Given this list of marker genes DUOXA2, GLI2, CDKN1C, SH3PXD2B, BMPER, ARX, LRP2, TG, CHUK, HSD17B4, LMNA, FIG4, KCNQ1OT1, HOXD13, PEX26, ETFDH, COL11A1, NDUFAF3, TWIST1, RNU12, VDR, TSHB, KCNQ1, EP300, DICER1, INTU, MTOR, MEG3, IGF2, MASP1, FLNA, ALG8, SEC23A, PIGQ, PEX19, PTDSS1, ACTB, TALDO1, PAM16, MPDU1, WNT5A, ANTXR1, PEX2, TPO, ALG9, PEX12, NSUN2, DDR2, COX5A, IYD, POLR3A, PEX14, FGFR2, SIX2, CDH11, CDC45, GLI3, FAM20C, EBP, ATP7A, HNF1B, SHPK, PEX13, PPIB (peptidylprolyl isomerase B), PROP1, NEB, POR, WT1, HPGD, RTL1, KIF7, LTBP4, LIG4, SETBP1, ETFA, RUNX2, COL1A2, KLHL40, ZSWIM6, ACTG1, PPP2R5D, PEX3, COG4, AGT, ADAMTS2, PEX6, NPHP3, DUOX2, P3H1, AGTR1, HESX1, MID1, FOXE1, NKX2-1, NEPRO, AMER1, DSE, PEX5, REN, RECQL4, DEPDC5 (DEP domain containing 5, GATOR1 subcomplex subunit), IFT140, MAF, DDX3X, PAX8, FGFR3, USP7, INPPL1, FAT4, GJA1, POU1F1, LHX3, CYP27B1, LMOD3, SKI, PIEZO2, SLC34A3, CLCN3, ASXL3, SPTBN1, GPX4, DCHS1, CAV1, ETFB, SLC25A24, ALG1, COL1A1, GLIS3, PIGA, KLF1, NSMCE3, SLC5A5, SLC26A4, COG8 (component of oligomeric golgi complex 8), ACTA1, PEX10, CHST14 (carbohydrate sulfotransferase 14), COL11A2, NAA10, HRAS, CRTAP, CREBBP, NKX2-5, ALPL, ZMPSTE24, ZFX, DVL1, SMG9, B3GLCT, DLK1, PYCR1 (NCBI Gene Id 5831), ACE, CBFB, TSHR, VPS35L, CCDC22, MSX2, ALDH18A1, PEX16, CYP2R1, SOX9, PEX11B, KLHL41 (kelch like family member 41), PEX1, MED12, PCGF2, LHX4, MVK, RBM10, GNPAT, LHX1, ROR2, ATP6V0A2, here is a description of the gene set: studied in species Homo sapiens In newborns, the two frontal bones, two parietal bones, and one occipital bone are joined by fibrous sutures, which form a small posterior fontanelle, and a larger, diamond-shaped anterior fontanelle. These regions allow for the skull to pass the birth canal and for later growth. The fontanelles gradually ossify, whereby the posterior fontanelle usually closes by eight weeks and the anterior fontanelle by the 9th to 16th month of age. Large fontanelles are diagnosed if the fontanelles are larger than age-dependent norms. Human Gene Set: HP_LARGE_FONTANELLES Large fontanelles